The following is a description of a gene set: Catalysis of the release of ammonia by the cleavage of a carbon-nitrogen bond or the reverse reaction with ammonia as a substrate. species: Mus musculus Mouse Gene Set: GOMF_AMMONIA_LYASE_ACTIVITY, and this is the list of marker genes: Ftcd, Srr, Hal, Sds, Sdsl